Given this list of marker genes Chmp5, Hid1, Chmp4b, Chmp3, Chmp2b, Chmp7, Chmp2a, Chmp6, Chmp1b2, Vps16, Chmp1b, Chmp1a, Chmp4c, here is a description of the gene set: Merging of two or more vacuoles, or of vacuoles and vesicles within a cell to form a single larger vacuole. species: Mus musculus Mouse Gene Set: GOBP_VACUOLE_FUSION